Given this list of marker genes Xbp1, Il10, Bcl6, Ddrgk1, Lilrb4a, Itm2a, Enpp1 (NCBI Gene Id 97628), Nkx2-3, Nfkbiz, Lgals1, Il2, Lgals8, here is a description of the gene set: Mouse Gene Set: GOBP_PLASMA_CELL_DIFFERENTIATION studied in species Mus musculus The process in which a B cell acquires the specialized features of a plasma cell. A plasma cell is a lymphocyte which develops from a B cell and produces high amounts of antibody.